Given this list of marker genes Trav3-3, Trav4-1, Gm5408, Or5au1, Trav5-4, Trav6-3, Arhgef40, Acin1, Trav4d-4, Traj33, Trav12-2, Traj3, Snord8, Traj4, Trav16n, Traj27, Traj53, Traj56, Trav5d-3, Trav4d-3, Supt16, Traj59, Gm36448, Traj48, Trdd1, Gm6755, Trav6d-6, Trav9n-2, 1700123O20Rik, Trav8-1, Rem2, Or4e2, Traj28, Traj19, Trav14d-1, Trav3-4, Trav7n-4, Trav15-1-dv6-1, Trav13n-4, Trav5-1, Trav4-3, Trav15n-2, Trav3n-2, Trav16, Trav15n-3, Trav15-2-dv6-2, Trav5n-3, Prmt5, Trav13d-2, Trav8n-2, Traj13, Gm22354, Traj38, Trav13-3, Or10g1b, Trav13d-4, Trav13-1, Gm17772, Trav15d-3, Trav7-5, Psmb11, Traj22, Psmb5, Trav8d-2, Traj44, Traj20 (NCBI Gene Id 100124369), Hnrnpc, Trdj2, Tmem253, Trav3d-2, Traj31, Or10g3, Mmp14, Trav9d-1, Rpgrip1, Gm30275, Trav12n-2, Trav9d-4, Traj11, Trav5n-2, Traj51, Traj25 (T cell receptor alpha joining 25), Trav7d-5, Or10g1, Mir6948, Trav18, Cmtm5, Trav7d-4, Gm3922, Traj26, Traj8, Traj9, Traj55, Slc7a7, Mir208a, Tox4, Traj21, Gm8704, Traj49, Traj36, Traj54, Traj52, Trav9d-2, Traj43, Trav4-2, Gm16617 (NCBI Gene Id 100502764), 4931414P19Rik, Il25, Gm43305, Trav9-1, Traj45, Cebpe, Rps19-ps1, Traj12, Trav12-1, Ppp1r3e, Gm8865 (predicted gene 8865), Gm23758, Trdc, Zfp219, Trav3d-3, Cirop, Chd8, Trav12d-2, Ajuba, Traj42, Trav9n-4, Traj47, Abhd4, Trav5-2 (T cell receptor alpha variable 5-2), Trav14d-3-dv8, 4930579G18Rik, Trav13n-3, Gm30214, Trav7d-2, Gm10366, Trav12d-1, Trav23, Cdh24, Traj29, Trav9-2 (T cell receptor alpha  variable 9-2), Slc7a8, Trav13n-2, Trav7-2, Trav6d-4 (T cell receptor alpha variable 6D-4), Trav14-1, Trav8d-1, 5330426L24Rik, Trav19, Trdd2, Trav4n-3, Trdv2-2, Trav12-3, Trav6-7-dv9, Trav13n-1, Traj46, Traj58, Sall2 (spalt like transcription factor 2), Trav8-2, Trav13d-3, Trav13-5 (NCBI Gene Id 219060), Trav7d-3, Trav1 (NCBI Gene Id 633641), Trav14-2, Trav14n-1, Rnf212b, Gm26590, Trav7n-6, Trav12n-1, Or6e1, Trav7-4, Traj15, Trav4d-2, Trav9d-3, Trav11d, Gm3945, Mir686, Trdv1, Rps19-ps2, Trav6n-6, Trav6-1, Mrpl52, Traj6, Trav6-6, Mettl3, Traj23 (NCBI Gene Id 100124366), Trav14n-3, Traj7, Trdv3, Trdv2-1, Traj34, Trav7-6, Trav17, Or4e5, Traj5, Traj24, Haus4, Trav5d-2, Bcl2l2, Trav5d-4, Traj39, Trav6n-5, Traj35, Gm8586, Trdv5, Traj57, Traj41, Trav16d-dv11, Pabpn1, Trav3-2, Trav14-3, Trav9-4, Traj30, Trav4-4-dv10, Or4e1, Trav21-dv12, Traj1, Trav4n-4, Trav14d-2, Trav6n-7, Trav6-4, Efs, Trav6-5, Traj32, Trav10d, Trav15n-1, Lrp10, Slc22a17, Trdj1, Trav15d-1-dv6d-1, Trav13-2, Gm6740, Trav15d-2-dv6d-2, Trac (T cell receptor alpha constant), Trav14n-2, Trav5n-4, Homez, 5430430K15Rik, Trav13-4-dv7, Trav11, Trav15-3, Trav13d-1, Gm26328, Trav10, Trav10n (NCBI Gene Id 667626), Traj60, Traj17, Trav6d-7, Trav9n-3, Trav11n, Traj50, Trav20, Rab2b, Oxa1l (NCBI Gene Id 69089), Traj61, Trav9n-1, Trav6-2, Traj14, Or10g3b, Dad1, Trav3-1, Trav12-4, Trav6d-5, Trav7n-5, Trav7d-6, Trav2, Trdv4, Traj18, Traj16, Trav22, Trav6d-3, Trav7-1, Traj40, Gm4742, Gm18711, Traj2, Gm36382, Trav3n-3 (NCBI Gene Id 634003), Rnu6-ps1, Traj37, Trav12d-3, Trav7-3, Trav12n-3, here is a description of the gene set: Mouse Gene Set: chr14C2 species: Mus musculus